Given this list of marker genes ANAPC1, TMEM270, COL5A2, RAB23 (RAB23, member RAS oncogene family), DONSON, GDF5, CDT1, NLRP3, TBC1D7, ORC4, FLNA (NCBI Gene Id 8272), ORC1, VPS37D, RECQL4, ESCO2, FBN2, GTF2IRD2, PIEZO2, BHLHA9, GP1BB, BUD23, PITX1, MAB21L2, EP300, TBL2, STXBP1, CSGALNACT1, LIMK1, EBP, EIF4H, COL1A1, COL9A3, UFD1, ORC6, DNAJC30, KIF22, CRELD1, HIRA, GTF2I, SHOX, UBR7, MAP1B, STX1A, COL9A1, ERMARD, TBX1 (T-box transcription factor 1), RBM8A, WNK3, PIK3CA, PRKACB, ZSWIM6 (NCBI Gene Id 57688), USP9X, BAZ1B, PRMT7, CDC45, AEBP1, SCARF2, WNT7A (NCBI Gene Id 7476), JMJD1C, COL12A1, YY1, DNMT3A, EXOC6B, SHH, GTF2IRD1, GMNN, COL5A1, BPNT2, COL2A1, CHRNG, CLIP2, ELN, SOX9, GJB2, ARVCF, COMT, ARF1, SEC24C, FZD2, LMX1B, RREB1, CANT1, ARFGEF2, AHDC1, SLC26A2, METTL27, ERI1, RYR1, XYLT1, NCF1, PKDCC, NOTCH2, PLOD1, KAT6B, ARID1B, OCRL, CDC6, TBX4, FKBP10, RFC2, RNU4ATAC, CREBBP (CREB binding protein), GJB6, COL9A2, CHST11, FKBP6, TMTC3, NEDD4L, FLNB, LMBR1, here is a description of the gene set: Abnormal patella morphology studied in species Homo sapiens Human Gene Set: HP_ABNORMAL_PATELLA_MORPHOLOGY Abnormality of the patella (knee cap).